The following is a description of a gene set: The developmental process, independent of morphogenetic (shape) change, that is required for an epithelial cell to attain its fully functional state. An epithelial cell is a cell usually found in a two-dimensional sheet with a free surface. Human Gene Set: GOBP_EPITHELIAL_CELL_MATURATION studied in species Homo sapiens, and this is the list of marker genes: NKX6-1, GDF11, CEBPA, BHLHA15 (basic helix-loop-helix family member a15), HOXA5, PGR, FEM1B, GPAT4, XBP1, EPAS1, HOXB13, TFCP2L1, GATA2, FOXA1, KDR, TMIGD1, FZD5, VEGFA, TGFB1, AKR1B1, TMEM79, HIF1A, SIX3, RFX3, KCNE1